Given this list of marker genes Derl1, Srpra, Derl2, Srp68, Derl3, Srp72, here is a description of the gene set: Mouse Gene Set: GOMF_SIGNAL_RECOGNITION_PARTICLE_BINDING Binding to a signal recognition particle. studied in species Mus musculus